The following is a description of a gene set: The chemical reactions and pathways resulting in the breakdown of peptides, compounds of 2 or more (but usually less than 100) amino acids where the alpha carboxyl group of one is bound to the alpha amino group of another. species: Homo sapiens Human Gene Set: GOBP_PEPTIDE_CATABOLIC_PROCESS, and this is the list of marker genes: NAALADL1, LVRN, MME, ADAMTS13, NPEPPSP1, ANPEP, CPQ, ECE1, LNPEP, ERAP2, CPA4, ENPEP, IDE, CTSH, TPP1, ACE, ERAP1, TRHDE, LTA4H (NCBI Gene Id 4048), NPEPPS (NCBI Gene Id 9520)